The following is a description of a gene set: Mouse Gene Set: GOBP_RESPONSE_TO_FIBROBLAST_GROWTH_FACTOR Any process that results in a change in state or activity of a cell or an organism (in terms of movement, secretion, enzyme production, gene expression, etc.) as a result of a fibroblast growth factor stimulus. species: Mus musculus, and this is the list of marker genes: Creb3l1, Ctnnb1, Epha10, Igf1r, Tbx2, Chrd, Pax6, Itgb1, Fgf2, Zfp36l2, Ephb1, Elk1, Fgf7, Frs3, Fat4, Rab14, Sfrp1, Ndnf, Epha3, Tbx1, Fgfr4, Nr4a1, Shisa2, Scgb1a1, Flrt1, Nog, Epha8, Epha4, Pdgfb, Churc1, Ndst1, Fgfbp1, Star, Fgf22 (fibroblast growth factor 22), Cd44, Tyro3, Mertk, Pdgfrb, Itgb1bp1, Klb, Npr2, Fgfr3, Kit, Fgf14, Pdgfra, Csf1r, Flrt3, Sulf2, Thbs1, Egr3, Met, Nrxn1, Epha6, Flt3, Fgf15, Kif16b (kinesin family member 16B), Erbb4, Gata3, Frs2, Sulf1, Lhx1, Egfr, Kdr, Fgf16, Epha2, Epha7, Crkl, Ntrk1 (NCBI Gene Id 97088), Insrr, Cxcl13, Flrt2, Ccl5, Flt4, Grb2, Ptpn1, Gpc1, Ephb2, Fgf21, Ier2, Ift80, Nptn, Fgfrl1, Wnt4, Ngfr, Epha1, Ddr2, Dll4, Fgf18, Runx2, Fgf5, Spry1 (NCBI Gene Id 24063), Trim71, Gclm, Cps1, Axl, Zfp36, Erbb2, Flt1, Casr, Musk, Fuz, Alk, Ror2, Ephb3, Wnt5a (wingless-type MMTV integration site family, member 5A), Hhip, Smoc2, Ntrk2, Fgfbp3, Insr, Gclc, Ros1, Fgf1, Zfp36l1, Fgfr2 (NCBI Gene Id 20946), Fam20c, Fgf3, Tek, Ddr1, Iqgap1, Ptpn11, Shcbp1, Fgf6, Tie1, Kl, Epha5, Postn (periostin, osteoblast specific factor), Tnc, Zdhhc16, Col1a1, Cep57 (centrosomal protein 57), Ntrk3, Sos1, Tcf7l2, Mst1r, Prkd2, Enpp1, Fgf8 (fibroblast growth factor 8), Kdm5b, Hyal2, Fgf4, Fgf20, Fgf23, Ofd1, Fgf12, Fgf9, Spry4, Apln, Ext1, Prdm14, Kcnc1, Ephb4, Rhod, Hyal1, Spry2, Fgf10, Lrit3, Fgfr1, Ret, Ext2, Dstyk, Fgf17, Ltk, Ccn2